The following is a description of a gene set: from publication Cui A, Huang T, Li S, Ma A, Pérez JL, Sander C, Keskin DB, Wu CJ, Fraenkel E, Hacohen N (PMID 38057668) Mouse Gene Set: CUI_MIGDC_IL_Y_RESPONSE_DN species: Mus musculus Cytokines mediate cell-cell communication in the immune system and represent important therapeutic targets. A myriad of studies have highlighted their central role in immune function, yet we lack a global view of the cellular responses of each immune cell type to each cytokine. To address this gap, the authors created the Immune Dictionary, a compendium of single-cell transcriptomic profiles of more than 17 immune cell types in response to each of 86 cytokines (>1,400 cytokine-cell type combinations) in mouse lymph nodes in vivo. A cytokine-centric view of the dictionary revealed that most cytokines induce highly cell-type-specific responses. For example, the inflammatory cytokine interleukin-1β induces distinct gene programmes in almost every cell type. A cell-type-centric view of the dictionary identified more than 66 cytokine-driven cellular polarization states across immune cell types, including previously uncharacterized states such as an interleukin-18-induced polyfunctional natural killer cell state. Genes negatively differentially expressed in cell type: MigDC (migratory dendritic cell) upon treatment with cytokine: IL-Y in mouse lymph nodes in vivo., and this is the list of marker genes: Uba52, Fosb, Hspa1a, H2-Q4, Hspa1b